The following is a description of a gene set: species: Homo sapiens Human Gene Set: REACTOME_NR1H2_NR1H3_REGULATE_GENE_EXPRESSION_TO_CONTROL_BILE_ACID_HOMEOSTASIS NR1H2 & NR1H3 regulate gene expression to control bile acid homeostasis, and this is the list of marker genes: RXRB, UGT1A3, FABP6, NCOR2, RXRA, NCOA1 (nuclear receptor coactivator 1), NR1H2, NR1H3, NCOR1 (nuclear receptor corepressor 1)